The following is a description of a gene set: Human Gene Set: GOBP_REGULATION_OF_ERYTHROCYTE_DIFFERENTIATION Any process that modulates the frequency, rate or extent of erythrocyte differentiation. studied in species Homo sapiens, and this is the list of marker genes: LYN, HIF1A, NCKAP1L, STAT5B, INPP5D (NCBI Gene Id 653796), FOXO3, ID2, HOXA5, MIR221, ACVR1B, MAFB, ZFP36, MAPK11, ISG15, KAT7, ANKRD54, TAL1, RHEX, ARNT, MIR222, MIR486-1, PRMT1, STAT3, MAPK14, SENP1, HSPA9, P4HTM, GATA1, SPI1, LDB1, HSPA1B, HMGB2, HSPA1A, MED1, ETS1, ZFP36L1, ZFPM1, ZNF16, ACVR2A, SMAP1, YPEL4, B2M, INHBA, KLF13, FAM210B, BRD1, STAT1, PRKDC, ABCB10, GATA2, STAT5A, CDK6, GLUL